The following is a description of a gene set: Many vaccines induce protective immunity via antibodies. Systems biology approaches have been used to determine signatures that can be used to predict vaccine-induced immunity in humans, but whether there is a 'universal signature' that can be used to predict antibody responses to any vaccine is unknown. Here we did systems analyses of immune responses to the polysaccharide and conjugate vaccines against meningococcus in healthy adults, in the broader context of published studies of vaccines against yellow fever virus and influenza virus. To achieve this, we did a large-scale network integration of publicly available human blood transcriptomes and systems-scale databases in specific biological contexts and deduced a set of transcription modules in blood. Those modules revealed distinct transcriptional signatures of antibody responses to different classes of vaccines, which provided key insights into primary viral, protein recall and anti-polysaccharide responses. Our results elucidate the early transcriptional programs that orchestrate vaccine immunity in humans and demonstrate the power of integrative network modeling. Genes positively correlated with antibody response in peripheral blood mononuclear cell in adults (18-45) (anti-polysaccharide antibody-correlation profile) after exposure to Menactra, time point 3D studied in species Homo sapiens from publication Li S, Rouphael N, Duraisingham S, Romero-Steiner S, Presnell S, Davis C, Schmidt DS, Johnson SE, Milton A, Rajam G, Kasturi S, Carlone GM, Quinn C, Chaussabel D, Palucka AK, Mulligan MJ, Ahmed R, Stephens DS, Nakaya HI, Pulendran B (PMID 24336226) Human Gene Set: LI_PBMC_MENACTRA_AGE_18_45YO_CORRELATED_WITH_ANTI_POLYSACCHARIDE_ANTIBODY_3DY_POSITIVE, and this is the list of marker genes: MAP3K8, HLA-DRB1, NFKBID, CCL20, IFNG, IL1B, ICAM1, HLA-DPA1, CSF2RA, HLA-B, TBXAS1, PTGS2, PDE4B, CD1A, IL4I1, HLA-DRB4, CYP1B1, HLA-A, CSF1R, CCL4, FUT7, CD9, TLR8, RIN2, SERPINB9, SLAMF8, RGL1, IL1RN, TMT1A, SAMSN1, PLXDC2, RTN1, ASGR2, HLA-DQA1 (major histocompatibility complex, class II, DQ alpha 1), HLA-DRA, CD83, TNFAIP6, HLA-F, CD1B, FAR2, CD1C, CXCL2, HLA-DPB1, PLAUR, CD86, PRKCD (NCBI Gene Id 5580), HLA-E, HLA-DMA, PCTP, BCL6, EBI3, TNF, GCH1 (GTP cyclohydrolase 1), HMOX1, TNFSF13B, HLA-G, RELB, TLR7, CD1D, ASGR1